Given this list of marker genes ADCY2, GTPBP4, C2CD4B, C4B, KLHDC8B, NDFIP1 (Nedd4 family interacting protein 1), SCFD1, ZBTB7B, CRISPLD2, MRPL1 (NCBI Gene Id 65008), GPR83, PTPN12, PDZK1IP1, SMG8, MAP3K14, CD2, SPPL2B, PDE11A, KLHL8, STK39, CD5, EXOC3L2, HMX3, TOR3A, HPS4, GNPNAT1, ELN (NCBI Gene Id 2006), ARHGAP20, EXT1, NFKB1, PRR16, STX11, CHRNA1, ASB2, JHY, CDX4, GPR137B, FGF12, NFATC4, GPX6, CD83, TTYH1, FAR1, POMGNT1, TRPM1, NRGN, C1QTNF12, LINGO2 (leucine rich repeat and Ig domain containing 2), CHL1, TP53BP1, DNAJB7 (NCBI Gene Id 150353), GLB1L, C3orf70, ENO3 (enolase 3), HSD17B12 (hydroxysteroid 17-beta dehydrogenase 12), ANK2, SLC15A1, RASAL1, SERPINE2, SLC24A1, LITAF, CYP4V2, LRRC36, SNX12, KCNA7, C1QL2, PRMT2, PENK, NLRP4, RSPO1 (R-spondin 1), SEPTIN14, MMP9, MORF4L1 (NCBI Gene Id 10933), PTTG1IP, HIVEP3, TPH2, ST7L, NR2F2, NEFM, ZNF608, BBS12, OPTN, NRN1, RGS16, FUNDC1 (FUN14 domain containing 1), LASP1, CERS4, GPR153, DUSP5, ADCY4, IKZF2, SDF4, CLDN22, SMOX, KCNS2, OTX1, MAST4, PRR5L, IL21, SYTL2, CCR8, CCND2, HHAT, MAGEB16, REC8, IZUMO1R, TAGLN, TNFRSF9, OMA1, LHFPL6, RBM28, TFPI, RAB8B, FARP2, GTPBP2, CDKL2, ZBED5, IER5, SLC12A8, CD6, C2orf72, MFSD2A, ZNF821, KCNN4, KYNU, TNIK, CARMIL3, RAP2A, PRDM16, ZCCHC12, CAMK2D, SLC35D3 (solute carrier family 35 member D3), DAGLB, CD247, FAM131A, TRIM3, MED22, USP9Y, TTLL11, FAP, ZNF823, TPD52, PYROXD2, VILL (villin like), KRTAP2-4, ATCAY, SLC2A10, RNFT1, ETV5, ADAMTSL2, FCER2, PRLR, PTGER3, CSF2, GPR160, ONECUT3, SPATA3, LCMT1, IPO4, AK7, HOXC4, PDCD1LG2, LAD1, GPC2, PCDHB6, TC2N, ZNF467, POU2AF1, SEMA3D, AKR1C3, TBX22, TSC22D1, MAPK12, WNT10A, AQP9, TSPAN31, TUSC3, GOT1, SLC16A10, ITIH5, MCOLN3, PIK3R3, SNX31, FGF21, KCTD14, SMAD6, FAM110B, CAP2, PARP8, CBLN2 (NCBI Gene Id 870), TNK2, MYH7B, PCDHB3, JAZF1, ST3GAL5, ADORA2B, CMYA5, TBX1 (NCBI Gene Id 7413), XCL1, here is a description of the gene set: Genes up-regulated in comparison of SP2 thymocytes versus SP3 thymocytes. species: Homo sapiens from publication Teng F, Zhou Y, Jin R, Chen Y, Pei X, Liu Y, Dong J, Wang W, Pang X, Qian X, Chen WF, Zhang Y, Ge Q (PMID 22022412) Human Gene Set: GSE30083_SP2_VS_SP3_THYMOCYTE_UP After positive selection in the thymus, the newly generated single positive (SP) thymocytes are phenotypically and functionally immature and undergo apoptosis upon antigen stimulation. In the thymic medullary microenvironment, SP cells progressively acquire immunocompetence. Negative selection to remove autoreactive T cells also occur at this stage. We have defined four subsets of CD4 SP, namely, SP1, SP2, SP3, and SP4 that follow a functional maturation program and a sequential emergence during mouse ontogeny.We used microarray to detail the global programm of gene expression during the maturation of murine CD4 single positive thymocytes